Given this list of marker genes H3C1, ANAPC5, H2AC4, H4C1, H2BC15, POLE3, ORC3, CDC16, DBF4, H2BC26, PSMB3, UBE2C, PSMD13, PSMD14, PSMC6, ANAPC15, PSMB5, PSMA1, ORC2, KPNA6, H2BC10, PSMC3, GMNN, H4C6, PSMA2, MCM3, H4C2, H3-3A, ANAPC16, UBC, CDT1, H2BC12L, H2AC8, MCM4, H2BC17, CDC23, H2BC8, H2AC19, PRIM2, H3C10, MCM2, H2AC20, H2BC11 (NCBI Gene Id 8970), POLA1, H4C4, KPNA1, H4C15, H2AC14 (H2A clustered histone 14), PSMC5, FZR1, CDC45, CDC6 (cell division cycle 6), PSMC4, PSMA5, MCM10, UBE2S, H3C3, PSMD8, ANAPC1, H2BC9, ORC1, PSMB4, H4C3, H3C8, MCM6, ANAPC10, CDC26, H3C12, PSMD1, H4C13, PSMC2, H4C14, RPA3, PSMA6, H2BC3, H2AJ, H3C14, CDC7, H2BC12, H2AC7, ANAPC2, H4C8, H2AC6, H3C13, H2BC5, H3C15, CDK2, H2AB1, H4C11, PSMD12, RPA2, KPNB1, UBE2E1, PSMA4, PSMB2, ADRM1, H3C6, H4C16, PSMB1, H2BC13, SEM1, H2AC18, ORC4, UBB, H3-3B, POLE4, H2BC7, PSMB6 (NCBI Gene Id 95505), H3C2, H4C5, ORC5, H3C11, H2BC1, POLE2, H3C7, MCM5, MCM7, POLA2, UBE2D1, PSMA3, PSMD2, ANAPC7, RPS27A, POLE, H2BC21 (H2B clustered histone 21), H2AX, ORC6, H2BC14, PSMA7, ANAPC4, PSMB7, CDC27, PSMD6 (NCBI Gene Id 9861), H4C12, MCM8, RPA4, PSMC1, H2BC6, RPA1, ANAPC11, PSMD7, PRIM1, H4C9, PSMD11, H2BC4, PSMD3, UBA52, H2AZ2, H3C4, here is a description of the gene set: Human Gene Set: REACTOME_DNA_REPLICATION_PRE_INITIATION studied in species Homo sapiens DNA Replication Pre-Initiation